The following is a description of a gene set: species: Homo sapiens Human Gene Set: GOBP_REGULATION_OF_RESPONSE_TO_REACTIVE_OXYGEN_SPECIES Any process that modulates the frequency, rate or extent of response to reactive oxygen species., and this is the list of marker genes: SESN1, GCH1, BMP7, CD36, FBLN5, SESN2, SESN3, DHFRP1, DHFR, ADCYAP1R1, NFE2L2